The following is a description of a gene set: Reactome Pathway: Synthesis of PE electronically inferred by orthology from the curated human pathway studied in species Mus musculus part of: Glycerophospholipid biosynthesis This event has been computationally inferred from an event that has been demonstrated in another species.<p>The inference is based on the homology mapping from PANTHER. Briefly, reactions for which all involved PhysicalEntities (in input, output and catalyst) have a mapped orthologue/paralogue (for complexes at least 75% of components must have a mapping) are inferred to the other species., and this is the list of marker genes: Pcyt2 (NCBI Gene Id 68671), Chkb, Chka